Given this list of marker genes AGMAT, AZIN2, here is a description of the gene set: Agmatine is an amine formed by decarboxylation of L-arginine and hydrolyzed to putrescine. Agmatine binds to several target receptors in the brain and has been proposed to be a neuromodulator. Agmatine has the potential to serve in the coordination of the early and repair phase pathways of arginine in inflammation. species: Homo sapiens Reactome Pathway: Agmatine biosynthesis part of: Metabolism of polyamines